Given this list of marker genes IDH3B, PGAM1, TPI1, IDH1, PKM (NCBI Gene Id 8127), SDHB, MDH1, PCK2, SDHD, PFKM, PCK1, ACO1, ALDOA, ACO2, PGK1, ALDOC, ENO2, PFKP, GAPDH, LDHA, SDHA, SUCLG1, ENO1, IDH3G, FH, IDH2, here is a description of the gene set: Glycolysis and TCA cycle. Human Gene Set: MODULE_306 species: Homo sapiens